The following is a description of a gene set: An arrangement of closely apposed microtubules running parallel to each other. Human Gene Set: GOCC_MICROTUBULE_BUNDLE species: Homo sapiens, and this is the list of marker genes: MTCL1, TPPP, MARK2, ATAT1, NUMA1, TPPP3